Given this list of marker genes CNTLN, SETD7, DERL3, GBP6, DOK1 (docking protein 1), MRC1, NECTIN4, TAX1BP1 (NCBI Gene Id 8887), GRN, ST6GALNAC4, DNAJC5 (DnaJ heat shock protein family (Hsp40) member C5), PTCRA, LIMK1, ANGPTL2, ERP29, IL18RAP, C6orf62, RNF114, DUSP7, FABP4, UBA7, HAUS1, CYP4A11, WDR33, MX2, PRLR, TSPO, TMEM176B, ASB7, KLF6, MTARC2, RANBP1, PPIG, ST6GALNAC6, TSPAN17, WNK1, PNPT1, PAG1 (phosphoprotein membrane anchor with glycosphingolipid microdomains 1), CAMK1D, LAT2, NAA20, BTRC, SMAD4, CPNE3, ADAD1, ZFYVE26, NUPR1, HUS1, AHCYL1, HOXB13, ICAM1, PTPA, MCM10, EPB41, ST14, CRYBB2, RIN2, ARHGEF7, STRC, P2RY12, TOB1, CBR3, BHLHA15, TBK1, ZBTB20, FEZ2, GPR35, CCDC92, PLEKHF2, DNMT3A, CSF1, METTL8 (NCBI Gene Id 79828), NUP42, TAOK3, GPSM2, ZFAND5, NOTCH2, IRAG2, DEPTOR, HUNK, MYO1C, SELENOT, TFG, MRPL39, FAM120A, CRBN, RARS1, NONO, TOR3A, GCA, SPSB1, CSF2RB (NCBI Gene Id 3564), FGFR1, TFDP1, RNPEP, ADIPOR2, EID1, LRATD1, TIFA, TIMELESS, PTTG1, EVI5, KMT2E, TM2D2, ZNF354A (zinc finger protein 354A), CNGB3, GGA2, DDX4, MORC3, GCNT2, CCDC186, MKNK2, DNAJA1, BRWD3, MIA2, RGS1, TTC14, CTDSP2, PPDPF, HOXB9, ACTR6, MNT, HDAC7, PKIG, PLCB2, HACD4 (3-hydroxyacyl-CoA dehydratase 4), CDKN1B, KMT2D, FBXO25, MTBP, EHD2, CMIP, SEMA5A (NCBI Gene Id 9037), NAAA, CR1L, CRYM (NCBI Gene Id 1428), RFC1, TUBA8, ANKRD44, FOXO3, ODF2L, SCAMP2 (NCBI Gene Id 10066), RGS14, CD47, HMG20B, BRD4, CASQ2, LRRK1 (leucine rich repeat kinase 1), LAPTM4B, BATF2 (NCBI Gene Id 116071), ZNF213, STARD8, FAM32A, ARFGEF1 (ADP ribosylation factor guanine nucleotide exchange factor 1), PDLIM5, MATK, CMTM6, EEPD1, TMEM37, UQCRC2, CHTF18, PRPF38B, PTCH1, PRTN3, NTS, PLCG2, GLUL, THAP12 (NCBI Gene Id 9137), OXCT1, USP18, BTBD3, TPPP3, CSNK1A1, PLK2, IMPDH1, FRG1, VGLL4, ENDOG, CERT1, CTSC, TIMM10B, GNA13, ADGRV1, TFAP4, SERHL2, CUL4B, NUDT9, POLB, MRPS9, IGSF9, HOMER1, ATG16L1, SECTM1, PCNA, RSAD2, TPST1, MAPK8IP1, TTC39B, PTPRZ1, REEP3, here is a description of the gene set: Genes up-regulated in comparison of dendritic cells (DC) stimulated with poly(I:C) (TLR3 agonist) at 6 h versus DC cells stimulated with Gardiquimod (TLR7 agonist) at 6 h. mouse primary BMDCs were stimulated with tlr ligands and gene expression changes were profiled on Affymetrix arrays Human Gene Set: GSE17721_POLYIC_VS_GARDIQUIMOD_6H_BMDC_UP studied in species Homo sapiens from publication Amit I, Garber M, Chevrier N, Leite AP, Donner Y, Eisenhaure T, Guttman M, Grenier JK, Li W, Zuk O, Schubert LA, Birditt B, Shay T, Goren A, Zhang X, Smith Z, Deering R, McDonald RC, Cabili M, Bernstein BE, Rinn JL, Meissner A, Root DE, Hacohen N, Regev A (PMID 19729616)